Given this list of marker genes CLVS2, LHFPL2, TBC1D15, SUN2, ANKIB1, MYEF2, DCTN6, UBE2H, ATP6V1C1, CTHRC1, VAMP7, ZNF624, L3HYPDH (NCBI Gene Id 112849), TSNAX, CACNA1D, PCDH9 (protocadherin 9), OCRL, WBP4, NCOA2, UGT8, ETS1, ANKH, ARHGAP11A, PRMT3, ZNF470, RARRES1, SOX30, ZKSCAN8, ENKUR, PIWIL1, BCKDHB, NUDT10, NSD3, CNTN4, AHSA2P, FOXN2, EHBP1, EIF4A2, NR2E1, ACOT11, SLC6A4, COL4A4, TDRD15, CXCR6, TMEM236, NLN, F9, REPIN1, AP3B1, NTF3, here is a description of the gene set: Genes predicted to be targets of miRBase v22 microRNA hsa-miR-3146 in miRDB v6.0 with MirTarget v4 prediction scores > 80 (high confidence targets). from publication Chen Y, Wang X (PMID 31504780) species: Homo sapiens Human Gene Set: MIR3146